Given this list of marker genes MUC13, MUC20 (NCBI Gene Id 57550), MUC4, MUC12, GALNT3, MUC6, MUC7, MUC3A, MUC17, MUC16, MUC21, MUC1, MUC2, MUC3B, MUC5AC (NCBI Gene Id 730855), MUCL1, MUC15, MUC5B, MUC19, here is a description of the gene set: part of: Diseases associated with O-glycosylation of proteins species: Homo sapiens Reactome Pathway: Defective GALNT3 causes HFTC The family of UDP GalNAc:polypeptide N acetylgalactosaminyltransferases (GalNAc transferases, GALNTs) carry out the addition of N acetylgalactosamine (GalNAc) on serine, threonine or possibly tyrosine residues on a wide variety of proteins, most commonly associated with mucins. This is the initial reaction in the biosynthesis of GalNAc-type O linked oligosaccharides. This reaction takes place in the Golgi apparatus. There are 20 known members of the GALNT family, 15 of which have been characterised and 5 candidate members which are thought to belong to this family based on sequence similarity. The GALNT-family is classified as belonging to CAZy family GT27. Defects in one of the GALNT family genes, GALNT3 (MIM:601756), can cause familial hyperphosphatemic tumoral calcinosis (HFTC; MIM:211900). HFTC is a rare autosomal recessive severe metabolic disorder characterised by the progressive deposition of calcium phosphate crystals in the skin, soft tissues and sometimes bone. The biochemical observation is hyperphosphatemia, caused by increased renal absorption of phosphate. Some patients manifest recurrent, transient, painful swellings of the long bones with radiological evidence of periosteal reaction and cortical hyperostosis.